Given this list of marker genes NPPB, BRD3, LILRA4, ATP6V0A1, PLEC, MIR124-1HG, FKBP8, PFKFB3, TOB2, TYR, MADCAM1, FGFR1, APOM, TNNT1, NCDN, MALINC1 (NCBI Gene Id 124900193), KLHDC3, HNF1B, LYZL6, CYP3A5, PLA2G15 (NCBI Gene Id 23659), TMEM259, TRIO, HES2, FBLN1, MMP15, BTBD2, EPHA5, MAP3K11, SPIB, GAGE13, PPP5C, ATXN7L1, FGA, CAVIN1, ARID1A, EFNA2, here is a description of the gene set: from publication Kääb S, Barth AS, Margerie D, Dugas M, Gebauer M, Zwermann L, Merk S, Pfeufer A, Steinmeyer K, Bleich M, Kreuzer E, Steinbeck G, Näbauer M (PMID 15103417) Human Gene Set: KAAB_FAILED_HEART_ATRIUM_UP studied in species Homo sapiens To obtain region- and disease-specific transcription profiles of human myocardial tissue, we explored mRNA expression from all four chambers of eight explanted failing, and five non-failing hearts using high-density oligonucleotide arrays (Affymetrix U95Av2). We performed pair-wise comparisons of gene expression in the categories (1) atria versus ventricles, (2) disease-regulated genes in atria and (3) disease-regulated genes in ventricles. In the 51 heart samples examined, genes showed divergent distribution between atria and ventricles (genes with higher expression in atria, genes with higher expression in ventricles). Two hundred and eighty-eight genes were differentially expressed in failing myocardium compared to non-failing hearts (genes regulated in atria and ventricles, 172 regulated in atria only, genes regulated in ventricles only). For disease-regulated genes, down-regulation was 4.5-times more common than up-regulation. Functional classification according to Gene Ontology identified specific biological patterns for differentially expressed genes. Eleven genes were validated by RT-PCR showing a good correlation with the microarray data. Our goal was to determine a gene expression fingerprint of the heart, accounting for region- and disease-specific aspects. Recognizing common gene expression patterns in heart failure will significantly contribute to the understanding of heart failure and may eventually lead to the development of pathway-specific therapies. Genes up-regulated in atria of failing hearts (DCM and ICM) compared to healthy controls.